The following is a description of a gene set: Abnormal femoral head morphology studied in species Homo sapiens An abnormality of the femoral head. Human Gene Set: HP_ABNORMAL_FEMORAL_HEAD_MORPHOLOGY, and this is the list of marker genes: TRAF3IP1, COL10A1, TSHR, SLC5A5, COL2A1, COL1A1, PIK3C2A, COG1, RAB3GAP2, SKIC3, DUOXA2, BMP4, RET, CSPP1, COL1A2, GNPTG, CHST3, FZD2, COMP, COL11A2 (collagen type XI alpha 2 chain), EXTL3 (exostosin like glycosyltransferase 3), AIFM1, SLC26A2, LHX4, IFT140, EXT1, HSPA9, B3GALT6, UNC45A, PEX5, COL9A1, DYM, ADAMTS2, TBX4, TSHB (thyroid stimulating hormone subunit beta), BRF1, KIF22, RSPRY1, CREBBP, TRPS1, PHLDB1, TINF2, HS2ST1, PRG4, TRPV4, RAB33B, WNT5A, IDUA, RNU4ATAC, DVL1, IFNGR1, KIAA0586 (NCBI Gene Id 9786), FN1, SBDS, PCNT, CCN6, TPO, UFSP2, DVL3, DNAJC21, TONSL, TRAPPC2, ATP7A, NEK9, TG, DUOX2, SIL1, SRCAP, MATN3, ADAMTSL2, LHX3, MTX2, SLC2A10, RINT1, EFL1, EP300, TREX1, HESX1, ACAN, SMARCAL1, RAD21, IHH, CDC6, PLOD3, CANT1 (calcium activated nucleotidase 1), PROP1, POU1F1, SRP54, POP1, IYD, GLB1, SLC39A13